Given this list of marker genes BDNF-AS, H4C2, MRPL17, PSMG4, DDX46, CS, HNRNPC (heterogeneous nuclear ribonucleoprotein C), ZNF212, TARS2, ZDHHC12-DT, RHOF, MT1X, KIF16B, BORCS5, CLASP1, RBM6, ILF3, SEC11A, GOSR2, EEF1G, STAT6, NPM3, ILF3-DT, LRP6, ATP5IF1, FAM114A2, PPP1R11 (protein phosphatase 1 regulatory inhibitor subunit 11), FAM161A, SNORD27, CHEK1, RPP14, PLK3, POC1A, TUBA1B (NCBI Gene Id 88851), ANXA2, OXA1L-DT, RSL24D1, RPPH1, WDR82, LOH12CR2, SRSF5, TUBB2B, TRIP12, MTERF1, SSBP1, MALINC1, COMMD9, CHD2 (NCBI Gene Id 283680), RNU4-2, GCDH, PSMB7, RN7SKP193 (NCBI Gene Id 106479181), MTHFR, KICS2, NCBP2, POLR3F, SERAC1, MED11, ICE1, MRPS27, DYRK2, NASP, IMP4, MUC13 (mucin 13, cell surface associated), H3C6, RNASEK, ENTPD1-AS1, PPP2CA, H2BC26, SRFBP1, MRPL49, RNASEK-C17orf49, ZWILCH, CLCN6 (chloride voltage-gated channel 6), FAM185BP, CYP51A1, RPL26L1-AS1, TRMT11, PPP4R3B-DT, CENPP, TSPAN1, TXN2, SLC12A9-AS1, SLC39A11, MTAP, ZDHHC12, SAE1, MRNIP, HTD2, LGR5, IL1R2, BLOC1S1, FAM200A, NOP2, CCDC115, TUBA1B-AS1, PPP2CA-DT, LARS1, ZNHIT1, ACTN4, RSRP1, MCCC1, TMEM94, C1orf226, KRIT1, AGAP2-AS1, FAU, SNORD25, EIF4A2, FGFR1OP2, CAPZA2, OXA1L, GCN1, VPS29, SNHG1, DMXL2, ALG5, PDIA4, PLXDC1, ATF6B, DCAF17, LINC02851, TNFSF9, CNPY2-AS1, RAD9B, PRMT5, ANKIB1, MED28, SGO2, SNORA13, CPD, GFM2, SLC3A2 (NCBI Gene Id 6520), WBP2, RPS17, POC5, ENSG00000241525, RAD51-AS1, SPATA24, UBAP2, SNORD26, LINC01023, RIF1, RMDN3, LNPEP, GPR19 (NCBI Gene Id 2842), IMPDH2, RABIF, PPWD1, BRD8, MED28-DT, KRT8, GNAL, CSNK1G1, NUCKS1, METTL8, COX7A2L, PPP4R3B, PDCD6IP, SERTAD2, CDK2AP2, SLC12A9, UBAP1, ZC3H6, RPL26L1, MTHFS, SFR1, ERCC5, NSA2, RN7SKP114, RPL8, ELL3, EARS2 (NCBI Gene Id 124454), LIN7C, CANX, RPL19, CCNB1, INTS13, ZNF487, MAP3K5, PLOD3, APC, MRPS18C, EXOSC8, LINC00513, MRNIP-DT, CENPK, TNPO3, ERCC1, WDR36, NCBP2AS2, CCDC146, PJA2, IQCD, PET100, VPS50, CLUH, RPL4, H4C12, HSD17B6, PRMT5-DT, STARD3, EPB41L4A-AS1, NOL8, ITGA7, USP53, SIRT4, HELQ, H4C4, UTP25, GMNN, CYP51A1-AS1, XAB2, MFAP3, GLYCTK, GOSR2-DT, REXO2, DZANK1, UNC45A, ZSCAN2, RNF13, LUC7L2, HELB, SDR39U1, TM2D1, NACA, ASH2L, UBFD1, DHDDS, LENG9, TIMM44, N6AMT1, CD55, H2AC25, TPCN1, PBX3-DT, TAPBPL, SKIC3, PNPLA6, KDM3A, ARSK, CD27-AS1, RBM22, USP8, POLDIP3 (NCBI Gene Id 84271), H2AC7, CCDC107, CDK4, SMIM15-AS1, EML6, PARP2, LINC00431, WEE2-AS1, CTDNEP1, PTCD2, GSS, FBXO36, SRSF1, VEZF1, DTX4, LINC02320, H2BC7, KANSL2, SLC25A42, RAD51, GTF2IRD1P1 (GTF2I repeat domain containing 1 pseudogene 1), KIF2C, SF3A3, PURA, SLC33A1, RGS17P1, MCTP2, LIAT1, PRIM1 (DNA primase subunit 1), ATG16L2, TPI1P2, here is a description of the gene set: Genes containing one or more binding sites for (HOXA10) in their promoter regions (TSS -1000,+100 bp) as identified by GTRD version 20.06 ChIP-seq harmonization. species: Homo sapiens Human Gene Set: HOXA10_TARGET_GENES from publication Yevshin I, Sharipov R, Kolmykov S, Kondrakhin Y, Kolpakov F (PMID 30445619)